The following is a description of a gene set: studied in species Mus musculus The process of regulating the proliferation and elimination of B cells such that the total number of B cells within a whole or part of an organism is stable over time in the absence of an outside stimulus. Mouse Gene Set: GOBP_B_CELL_HOMEOSTASIS, and this is the list of marker genes: Sos2, Ahr (NCBI Gene Id 193333), Il7r, Rc3h2, Spns2, Rc3h1 (RING CCCH (C3H) domains 1), Ikbkg, Bak1, Tnfrsf13b (NCBI Gene Id 80595), Sash3, Bbs4, Bbip1, Bcl2a1a, Ikbkb, Ada, Cd44, Foxp3, Vpreb1b, Pkn1, Vpreb1a, Casp3, Gapt, Bcl2, Caml, Mef2c, Bcl2l11, Ppp2r3c, Cd74, Pik3cd, Sh2b2, Dock11, Hif1a (hypoxia inducible factor 1, alpha subunit), Nckap1l, Tnfrsf13c, Bax (BCL2-associated X protein), Traf3ip2, Bcl10, Mif, Lyn, Abl1, Tnfaip3, Sos1 (SOS Ras/Rac guanine nucleotide exchange factor 1), Enpp1, Tnfsf13b, Dock10, Pirb